The following is a description of a gene set: X-linked recessive inheritance studied in species Homo sapiens A mode of inheritance that is observed for recessive traits related to a gene encoded on the X chromosome. In the context of medical genetics, X-linked recessive disorders manifest in males (who have one copy of the X chromosome and are thus hemizygotes), but generally not in female heterozygotes who have one mutant and one normal allele. Human Gene Set: HP_X_LINKED_RECESSIVE_INHERITANCE, and this is the list of marker genes: MTM1, GATA1, TRAPPC2, PRPS1, MID1, SMC1A, MID2, CUL4B, CLDN2, POF1B, RAB39B, CFAP47, SLC9A6, SLC6A8, PHF8, AP1S2, AFF2, TIMM8A, FGD1, COL4A6, ARSL, CLCN5, EDA, MCTS1, F9, IL1RAPL1, MAOA, ATP7A, AR, GPC4, SLC9A7 (NCBI Gene Id 84679), ROM1, ABCD1, DOCK11, TAFAZZIN, CD40LG, OGT, EBP (EBP cholestenol delta-isomerase), HCFC1, PTCHD1, RBMX, HS6ST2, ATP2B3, FANCB, SH2D1A (SH2 domain containing 1A), SH3KBP1, LAS1L, PHKA2, OTC, ABCB7, KDM5C, IGSF1, FRMPD4, TSR2, CYBB, MED12, FGF13, DKC1, DMD, IGBP1, USP27X, C1GALT1C1, OFD1, FOXP3, PAK3, RS1, ALAS2, TAF1, AIPL1, UBE2A, MSN, SLC16A2, OCRL, DLG3, USP9X, BCORL1, EIF2S3, LRAT, BTK, STS, SYN1, OPN1MW, ARL6, NKAP, UBA1, NSDHL, AIFM1, MAMLD1, NYX, FAM50A, PHF6, MECP2, SMPX, ARX, CFP, IRS4, POU3F4, ATRX, MAGT1, GPC3, KLHL15, L1CAM, ATP11C, RPL10, BRWD3, IQSEC2, ARHGEF9, BGN, ZC4H2, UPF3B, CNGA1, F8, ATP6AP2, OPHN1, IL2RG, FGF16 (NCBI Gene Id 8823), THOC2, HPRT1, AMMECR1, TMLHE, NR0B1, STAG2, NDP, PDE6G, DNAAF6, ZIC3, SYP, CRX, AVPR2, PHKA1, FTSJ1, SASH3 (NCBI Gene Id 93952), SSR4, GJB2, NAA10, FLNA, IDS, WAS, PGK1, BCAP31, NDUFA1, CCDC22, FHL1, CSTF2, SMS, PLP1, DDX3X, CFAP418, RLIM, LAGE3, IKBKG, MAGED2, GRIA3, TEX11, OTUD5, RPGR, CACNA1F, GK, TSPAN7, POLA1, GJB6, OPN1LW, RBP3, VMA21, WNK3, GPR143, CHRDL1, KIF4A, ATP6AP1, GLA, PQBP1, RBM10, ANOS1, PIGA, CLRN1, NONO, MBTPS2, GPRASP2, ELF4, XIAP, TLR7, EMD